Given this list of marker genes Cwh43 (NCBI Gene Id 352951), Gper1, Jak2, Src, Ywhaz, Hsp90ab1, Glul, Hnf4a, Cav2, Ilrun, Nmd3, Bmp4, Akt1, Cdk1, Gsk3b, Ormdl3, Tert, Lats1 (large tumor suppressor), Prkd1, Mapk14, Nup58, Tyk2, Nutf2-ps1, Pinx1, Shh, Pin1rt1, Card10, Rab23, Ins2, Pik3r1, Ei24, Hcls1, Tesk1, Mark3, Stk11, Ptpn5, Fbxo4, Glis2, Hsp90aa1, Fermt1, Psen1, Atp13a2, Uaca, Apod, Otud7b, Mavs, Lmna, Gbp4, Ogt, Zpr1, Ubr5, Ppp3cb, Mtor (NCBI Gene Id 80612), Edn1, Angpt1, Polr1a, Mfhas1, Gli3 (GLI-Kruppel family member GLI3), Fermt2, Ufm1, Pkig, Tmem98 (transmembrane protein 98), Zc3h12a, Jak1, Lzts2 (NCBI Gene Id 226154), Lamtor5, Dtx3l, Nf2, Nolc1, Lilrb4b, Nvl, Ptpn22, Smo, Akap5, Zic1, Ngfr (nerve growth factor receptor (TNFR superfamily, member 16)), Cabp1, Rassf5, Agtr2, Sumo3, Hdac3, Efcab7, Ran (RAN, member RAS oncogene family), Tnfrsf1a, Parp1, Hm629797, Dclk3, Chp2, Pin1, Mcrs1, Ipo7, Crebbp (CREB binding protein), Trim29, Chp1, Nup54, Rbm22, Sirt6, Parp9, Nfkbia, Cdh1, Nf1 (neurofibromin 1), Ifng, Dclk2, Prkcd, Brca1, Sesn2, Nutf2, Trim40, Pik3r2, Larp7-ps, Cacnb4, Lilrb4a, Cdk5rap3, Il6, Dclk1, Trim8, Lep, Limk2, Wwtr1, Tardbp, Mapk1, Ctnna1, Pkia, Flna, Hyal2, Akap1, Ywhab, Ep300, Cd36, Htt, Yap1, Sin3a, Ins1, Mdfic, Bag3, Eif2ak3, Epm2a, Sirt1, Tcf7l2, Mepce, Tfrc, Tgfb2 (transforming growth factor, beta 2), Dmap1, Tpr, App, Cd2ap, Npm1, Cdkn2a, Tek, Ipo5, Xbp1, Hnrnpm, Larp7, Sumo1, Lats2, Park7, Ptgs2, Maged1, Nup62, Ect2, F2, Jup, Trim28, Fyn, Cldn18, Tgfb1, Prkcq, here is a description of the gene set: studied in species Mus musculus Mouse Gene Set: GOBP_REGULATION_OF_PROTEIN_LOCALIZATION_TO_NUCLEUS Any process that modulates the frequency, rate or extent of protein localization to nucleus.